Given this list of marker genes TMBIM1, STON2, SNW1, LUC7L3, SLC18A1, AMOT, SLC26A9, RUNX1T1, TBX5 (T-box transcription factor 5), CCL27, TUBB2B, TRMT44, LHX6, FHL3, PSD4, FOSL2, PHOX2A, PAX2, ESRRG, ADM, PPT2, HCN1, PLXNB3, ANKS1B, HPSE2, SUSD1, EPOR, JUN, TRIM10, RAP1B, BSN, FHL2, PFKFB1, BPGM, CDIN1, LMO2, BMP10, AIF1L, LIX1, COL4A3, ZNF219, ABCA12, ZFPM1, IPCEF1, SYT7, LCAT, TSPAN12, IL22, GFRA3, WNT11, NRXN3, TDRD5 (NCBI Gene Id 163589), AMFR, PPM1E, ADORA3, MMP23A, SCUBE3, PNLIPRP2, FTH1, CAPN1, GATA1, ICAM4, KCNK3, USP15, DCX, PPP2R3A, HMBS, PPARGC1A, KRT72, SIX1, PNLIPRP1, KLF12 (KLF transcription factor 12), H1-0, BMP6, TNFSF13B, TAFA1, PLAG1, TIAL1, SLC4A1, EPX, CDC42EP3 (NCBI Gene Id 10602), DCAF11, APOOL, UBE2F, CS, SGIP1, NECTIN2, SLC26A7, SLITRK2, ERG, IGFBP5 (NCBI Gene Id 3488), RHD, MYCT1, XPO6, ZBTB7A, RBPMS, DMTN, NREP (neuronal regeneration related protein), CALHM5, ROBO1, COL4A4, ISL1, NR5A2, GP2, SFRP5, PKLR, KCNH5, ADGRF5, MYRF, CACNA2D3, HS3ST5, EDN1, FABP2, RGN, VPS18, MOGAT2, HOXD1, HIC1, MASP1, JPH1, CPOX, CAB39, TNK2, MS4A2, PDZD2, POU4F2, PIP5K1B, KRT80, LYL1, TRIM15, BIN1 (NCBI Gene Id 274), MAP4K3, PRR34, INHA, ACKR1, GPR155, NECTIN4, CNN1, TRPS1 (NCBI Gene Id 7227), GUCA2A, ZBTB7B, PLEKHG6, MMP23B, HOXB6, RHCE, GSE1, FOXP2, PLA2G1B, GIP, NRP2, FMO1, EDA, HOXA1, HAMP, POFUT1, TSHB, EN1, CD34, FAM117A, SYNDIG1, MSX2, ECHDC2, PLAC1, KRT20, KIRREL2, KCNJ15, TNXB, FLI1, SKIDA1, DENND1B, CYB5R3, B3GALT2, PCDH9, PLAGL2, SUV39H1, CHCHD7, GATA6, CTNNA3, CLU, NOCT, SIK3, IL7, TACC1, SPINK4, ELAVL4, PRR18, PTGDR2, USH1G, MOS, AQP2, CPA1, OTOP2, CREB5, KDM3A, GATM, EPB42, DSPP, ENO2, CXCL13, SPRY4, PDGFRA, here is a description of the gene set: Human Gene Set: GATA_Q6 species: Homo sapiens Genes having at least one occurrence of the motif WGATARN in the regions spanning 4 kb centered on their transcription starting sites. This matches the GATA1 transcription factor binding site V$GATA_Q6 (v7.4 TRANSFAC).